Given this list of marker genes Elovl2, Elovl1, Pecr, Hacd4, Hsd17b12 (NCBI Gene Id 98865), Elovl3, Elovl5, Elovl7, Hacd1, Tecr, Abcd1, Elovl6, Hacd2 (NCBI Gene Id 70757), Elovl4, Hacd3, here is a description of the gene set: studied in species Mus musculus The elongation of a fatty acid chain by the sequential addition of two-carbon units. Mouse Gene Set: GOBP_FATTY_ACID_ELONGATION